The following is a description of a gene set: Urticaria Human Gene Set: HP_URTICARIA studied in species Homo sapiens Raised, well-circumscribed areas of erythema and edema involving the dermis and epidermis. Urticaria is intensely pruritic, and blanches completely with pressure., and this is the list of marker genes: NLRP12, WAS, SRSF2, ALDH3A2, ADGRE2, PLCG2, CBL, IL12A, FASLG, WIPF1, NLRP3, SDHB, TNPO3, SERPING1 (NCBI Gene Id 710), SPIB, IL12RB1, ERCC2 (ERCC excision repair 2, TFIIH core complex helicase subunit), ALPK1, SDHC, ERCC3 (NCBI Gene Id 2071), MVK (mevalonate kinase), POU2AF1, ANTXR2, GNB2, ASXL1, MBTPS2, IRF5, NLRC4, XPNPEP2, CBLB, SPINK5, SF3B4, KIT, HLA-DQB1, CPN1, CARMIL2, LYN, MYD88 (MYD88 innate immune signal transduction adaptor), CASP10, RAC2, HLA-DRB1, FAS, SLC27A4, TNFSF15, CBS, MMEL1, TET2, ELOVL4, IFIH1, ERCC5, ERCC4, RUNX1, FOXP3, SUPT16H